Given this list of marker genes SCN5A, FLNC, KCNJ5, KCNE2, MYL4, SCN3B, KCNA5, KCNJ2, KCNQ1, here is a description of the gene set: Permanent atrial fibrillation studied in species Homo sapiens Atrial fibrillation (AF) that cannot be successfully terminated by cardioversion, and longstanding (more than 1 year) AF, where cardioversion is not indicated or has not been attempted, is termed permanent. Human Gene Set: HP_PERMANENT_ATRIAL_FIBRILLATION